The following is a description of a gene set: studied in species Homo sapiens An increase in size of a blastocyst due to expansion of the blastocoelic cavity cell shape changes and cell proliferation. Human Gene Set: GOBP_BLASTOCYST_GROWTH, and this is the list of marker genes: UBTFL1 (upstream binding transcription factor like 1), NDEL1 (NCBI Gene Id 81565), RTF1, IGF1, ZNF830, CTR9, NBN, ZPR1, PELO, PALB2, SBDS, GINS1, GINS4, COPS2, INTS1, PRPF19, GRN, NCAPG2, ACVR1C (activin A receptor type 1C), BRCA2, SALL4 (spalt like transcription factor 4), RAD51B, CHEK1, TAF8